Given this list of marker genes KRAS, BRAF, HRAS, MAP2K1, ARAF, MAPK3, NTRK1, NRAS, MAP2K2, RAF1, MAPK1, here is a description of the gene set: studied in species Homo sapiens Human Gene Set: KEGG_MEDICUS_VARIANT_TRK_FUSION_KINASE_TO_RAS_ERK_SIGNALING_PATHWAY Pathway Definition from KEGG: TRK* -> RAS -> RAF -> MEK -> ERK TRK fusion kinase to RAS-ERK signaling pathway. Pathway ID: N00009. Pathway type: Variant. Pathway class: nt06274 Thyroid cancer.